The following is a description of a gene set: from publication Motenko H, Neuhauser SB, O'Keefe M, Richardson JE (PMID 26092688) Mouse genes annotated to increased colon adenoma incidence (MP:0002044) retrieved from the Mouse Genome Informatics database via MouseMine species: Mus musculus Mouse Gene Set: MP_INCREASED_COLON_ADENOMA_INCIDENCE, and this is the list of marker genes: Tlr2, Cdx2, Bub1b, Apc, Fpr2, Trp53inp1, Elavl1, Ptprt